Given this list of marker genes HAPLN2, HAPLN1, VCAN, HAPLN4, ACAN, BCAN, TNR, NCAN, PTPRZ1, HAPLN3, here is a description of the gene set: studied in species Homo sapiens A dense extracellular matrix (ECM) that forms around many neuronal cell bodies and dendrites late in development and is responsible for synaptic stabilization in the adult brain. Human Gene Set: GOCC_PERINEURONAL_NET